The following is a description of a gene set: Any process that increases the rate, frequency, or extent of the series of molecular signals generated as a consequence of a transmembrane receptor serine/threonine kinase binding to its physiological ligand. Mouse Gene Set: GOBP_POSITIVE_REGULATION_OF_TRANSMEMBRANE_RECEPTOR_PROTEIN_SERINE_THREONINE_KINASE_SIGNALING_PATHWAY species: Mus musculus, and this is the list of marker genes: Gdf5, Msx2, Acvr1, Rbpj, Synj2bp, Zeb2, Bmp5, Nup93, Bmp4, Fgf9, Snw1, Gdf11, Rnf111, Adissp, Tgfbr2, Bmp6, Bmp7 (NCBI Gene Id 12162), Pelo, Tgfb1, Eng, Npnt, Lgals9, Fbxl15, Scube3, Tbx20, Bmper, Lrg1, Bmpr2, Sdcbp, Jak2, Msx1, Cdkn2b, Kcp, Parp1, Thbs1, Gdf7, Bmp10, Men1 (multiple endocrine neoplasia 1), Cdkn1c, Gata6, Hes5, Tgfb2, Flcn, Gdf2, Gata4, Axin1, Acvrl1, Foxd1, Gipc1, Zc3h3, Acvr2a, Cdh5, Crebbp, Csnk2b, Glce, Smad2, Tgfbr1, Furin, Myocd, Itga8, Tsc22d1, Elapor2, Gdf6, Inhba, Twsg1, Cited2, Ngly1, Ube2o, Tgfb3, Hes1, Ccn1 (NCBI Gene Id 99596), Acvr2b, Ilk, Slc2a10, Notch2, Gpc3, Ep300, Tgfbr3, Tgfb1i1, Stk11, Atoh8, Crb2, Numa1, Dab2, Vsir, Fkbp8, Ark2c, Ing2, Pparg, Fermt1, Amh, Sulf1, Neo1, Bmpr1a, D130043K22Rik, Hipk2, Smad4, Zfp423, Smad3, Bmp2, Nodal, Sox11, Acvr1b, Hsp90ab1, Sh2b1, Hfe, Got1, Notch1, Kdr